The following is a description of a gene set: Transforming growth factor beta (TGF-beta) and platelet-derived growth factor A (PDGFAlpha) play a central role in tissue morphogenesis and repair, but their interplay remain poorly understood. The nuclear factor I C (NFI-C) transcription factor has been implicated in TGF-beta signaling, extracellular matrix deposition, and skin appendage pathologies, but a potential role in skin morphogenesis or healing had not been assessed. To evaluate this possibility, we performed a global gene expression analysis in NFI-C(-/-) and wild-type embryonic primary murine fibroblasts. This indicated that NFI-C acts mostly to repress gene expression in response to TGF-beta1. Misregulated genes were prominently overrepresented by regulators of connective tissue inflammation and repair. In vivo skin healing revealed a faster inflammatory stage and wound closure in NFI-C(-/-) mice. Expression of PDGFA and PDGF-receptor alpha were increased in wounds of NFI-C(-/-) mice, explaining the early recruitment of macrophages and fibroblasts. Differentiation of fibroblasts to contractile myofibroblasts was also elevated, providing a rationale for faster wound closure. Taken together with the role of TGF-beta in myofibroblast differentiation, our results imply a central role of NFI-C in the interplay of the two signaling pathways and in regulation of the progression of tissue regeneration. species: Mus musculus Genes up-regulated in MEF cells (embryonic fibroblast) upon stimulation with TGFB1 for 10 h. Human Gene Set: PLASARI_TGFB1_TARGETS_10HR_UP from publication Plasari G, Calabrese A, Dusserre Y, Gronostajski RM, McNair A, Michalik L, Mermod N (PMID 19752192), and this is the list of marker genes: SEMA7A, OTUD7A, IL18R1, KLHDC8A, PLK3, DUSP14, GJB2, ELAVL2, PRG4, ENDOD1, MYO1D, TNNT2, SFN, SERPINE1, CRISPLD2, GATM, HIP1R, JAG1, MICAL2, ANKH, FLT1, GFPT2, TIMP3, NFATC1, CHST11, JUNB, HEY1, GUCY1B1, PPP1R13L, IL11, PRAG1, TNFAIP3, GADD45B, TGFBR1, NRARP, FOXC2, IL6, NFIL3, SLC41A2, CRY1, MCAM, FGF18, TNC, CDH6, CCL20, PTHLH, CMKLR1, GPR84, PDE4DIP, KLHL29, PLAUR, ZNF469, NPPB, BHLHE40, ENPP1, PDGFA, GREM2, FOXS1, HCK (NCBI Gene Id 3055), NUAK1, UNC5B, PKP1, ENTPD7, EGR2, FSTL3, CSRNP1, INHBA, TGFB1, LMO1, CNN1, ALDH1A2, PRKAR2A, ARG1, LAS1L, CXCL14, IP6K1, GJB3, TMCC3, PMAIP1, SLC20A1, RNF149, ELN, SNAI1, ITGA5, PMEPA1, STK38L, MAFF, SPHK1, SIAH2, ADAM12, MEOX1, PVR, ABTB3, RASL11B, GPER1, STMN4, DUSP5, GAREM2, NES, NGF, PTGS2, ASS1, LIF, CARD10 (NCBI Gene Id 29775), UBE2G2, IVNS1ABP, MGLL, F2RL1, RNF19B, EREG (NCBI Gene Id 2069), ABCB1, NTF4, PTK2B, HBEGF, FGF21, ITGB3, BAIAP2L1, HECTD2, SPATA13, THBS4, HTR2B, MEGF10, LRRFIP1, CREB3L2, HSPA2, CTH, ALDH1A3, RBFOX1, KHDRBS3, CDYL2 (chromodomain Y like 2), FXYD6, TTC9 (NCBI Gene Id 23508), CX3CL1, VEGFA, NUAK2, KLF13, PAPSS2, IER2, OLR1, PLEKHG3, WNT9A, GALNT3, TSPAN2, PDGFB, DUSP6, MFSD2A, PRKG2, NEBL, BMAL1, GCH1, CSPG4, HEYL, PDGFC, TFPI2, SERP1, ANKRD1, FKBP5, CA6, ARC, LRP8, SLC2A1, GFOD1, MMP9, NIPAL1, HAS2, RGS16, PPP1R15A, LPIN3, HK2, OLFM2, FGF2, RUNX1, GJA3, ALS2CL (NCBI Gene Id 338373), CD40, PI4K2B, SOCS2, ACTA1, WNT11, HIVEP3, GCNT2, RAP1GAP2, CCN2, FOSL1, FLNB (NCBI Gene Id 8413), CXCR6, KCNK1, KCTD11, COL8A2, TNFRSF12A, FBXO32, IER3, CCL17, LRRC8C, FJX1, TNFRSF11B